The following is a description of a gene set: Any process that stops, prevents, or reduces the frequency, rate or extent of leukocyte apoptotic process. Mouse Gene Set: GOBP_NEGATIVE_REGULATION_OF_LEUKOCYTE_APOPTOTIC_PROCESS species: Mus musculus, and this is the list of marker genes: Vhl, Cd74, Mir363, Mir18b, Gas6, Ccl21f, Ghsr, Pnp, Mir106a, Cxcl12, Tsc22d3, Itpkb, Pdcd1, Il7r, Fcer1g, Ccl19-ps4 (NCBI Gene Id 100040035), Serpinb9, Cd27, Stat5a, Mir19b-1, Ccl19-ps5 (NCBI Gene Id 100039789), Blm, Ccl21b, Rag1, Tnfsf4, Mir20b, Rorc, Mir92-2, Pip, Fcmr, Axl (AXL receptor tyrosine kinase), Cd44, Ccl21d, Mir92-1, Arg2, Bcl2l1, Tnfrsf4, Fcgr2b, Ptcra, Mir93 (NCBI Gene Id 723885), Slc46a2, Dock8, Noc2l, Hcls1, Kifap3, Hsh2d, Fadd, Bmp4, Mif, Bcl2, Irs2, Ccl19-ps6, Nod2, Il2, Selenos, Il18, Slc39a10, St6gal1, Cxcr2, Jak3, Ccl21e, Mir19b-2, Ido1, Ccl19-ps1, Bcl2a1a, Bcl3, Mir25, Efna1, Bcl10, Ada (NCBI Gene Id 11486), Kitl, Bcl11b, Ccl5, Ccl19, Ormdl3, Mir106b, Aurkb, St3gal1, Ccl19-ps3, Gpam, Il3, Foxp1, Hif1a, Ccr5, Prkcq, Mertk, Ccr7, Ccl21a